Given this list of marker genes TIMM8A, SOX4, CCDC157, PDF, TNFRSF25 (TNF receptor superfamily member 25), BCKDHB, TSPAN3, RBM38, LYPD5, DNAJC21, ERBIN, EAF1, RPE, IRF4, IFI30, AXIN2, CASS4, TRMT9B, CD247, PLEKHF2, CNIH4, SULF2, SEPTIN10, TTBK2, BZW2, ARPC5L, SLC25A24, ZBTB2, GOLPH3L, C14orf119, ARFIP1, MCEE, CPM, FTO, LANCL2, TRPC3, TMCC3, GABARAPL2, NUP160, MTMR10, PPIL6, ATP8B2, ALOXE3, SQOR, RFFL, NDUFAF7, ABI2, ATRNL1 (NCBI Gene Id 26033), RAMP3, AIG1, CPSF3, CDC42EP2, YTHDC1, HS3ST3B1, CIMIP7, GPSM2, ASAH2, LDLRAP1, NTN4, MRPL50, IFI44L, LSM2, GMFG, SNN, PARP11, TGFBR2, SLC9A6, STK39, MAP3K5, GALK2, TES, INPP5B, BABAM2, STMN1, IFT57, UBE2E3, SNAPC2, LACTBL1, CERS6, GABRR2, BDH1, SUPT7L, PRELID1, HNRNPLL, E2F2, ZNF569, PRR14L, RBM47, SPMIP7, CHURC1, RASSF3 (NCBI Gene Id 64500), NAA16, DTX2, CRMP1, ZSWIM2 (zinc finger SWIM-type containing 2), ALDOC, CERS4 (NCBI Gene Id 79603), FRMD6, SEC14L5, KIF24, POLR3E, ELAVL2, SEC11A, ENTREP1, SRSF3, RGMB, CYTIP, UBQLN1, NXPE3, SNX25, CCM2, DNAJC6, TMCC1, TNFRSF1A, NYAP1, KRT20, BRMS1L, XPNPEP1, CAND2, ZNF280B, TUBA4A, GFER, TGIF1, YPEL2, CYRIA, CYP2D6, TFE3, STT3B, CCDC112, UQCRC2, SLC25A23, MANSC1, JOSD2, KCND3, ACSL1, HADH, KIF3A, GNGT2, CAMKK2, TMEM267, LRRC42, SAPCD1, IFIT2 (interferon induced protein with tetratricopeptide repeats 2), GTF2A2, MAP2K4, RIPOR2, PSAT1, ZFAT, BORCS8, ACVR1B, UPF3A, SLAIN2, GATA3, PIM1, FAM234B, PWWP2B, LDAH, RPA1, DUSP1, ZNRF1, ST3GAL2, BRSK2, CDK2, AFTPH, TM2D3, CASP1, ZNF467, CSNK1G3, GIMAP4, SHLD1, POLR2M, REV1, PLK3, SNRPC, PTGIR, PHLPP1, RASGRP2, NCMAP, SLC30A1, CRLF3, KRBA1, CHRDL1, ZBTB18, SREBF2, ASNSD1, ACVR2B, TMUB1, PRR13, DLEU7, HIVEP2, PRDX4, SAV1, SLC48A1, MFHAS1, ACSL3, RHBDL3, NT5C3A, TUBGCP6, IMPA1, GLS, here is a description of the gene set: Genes up-regulated in comparison of untreated CD4 T cells versus CD8 T cells treated with leukocyte costimulatory blockade antibodies. Human Gene Set: GSE26669_CD4_VS_CD8_TCELL_IN_MLR_COSTIM_BLOCK_UP from publication Pearl JI, Lee AS, Leveson-Gower DB, Sun N, Ghosh Z, Lan F, Ransohoff J, Negrin RS, Davis MM, Wu JC (PMID 21362570) To elucidate the gene expression “footprint” of antigenically challenged T-cells which had been treated with anti-LFA-1, CTLA4Ig, anti-CD40-ligand antibodies, we performed microarray gene expression analysis comparing the expression profile of costimulatory blockade treated and untreated responder T-cells. studied in species Homo sapiens